Given this list of marker genes Cadm2, Pcmtd1 (protein-L-isoaspartate (D-aspartate) O-methyltransferase domain containing 1), Gvin3, Inpp4a, Ube2c, Slitrk2, Rabl3, Col11a1, Sparcl1, Cfl2, Fsd1l, Nup155, Samsn1, Bicd1, Mmd, Or51m1, Akap6, Ppp3ca, Cpsf6, Klhl23, Papola, Arhgap42, Man1a, Cyc1 (NCBI Gene Id 66445), Btg2, Plppr4, Sgip1, Gpr85, Scai, Pank3 (NCBI Gene Id 211347), Zfp36, Pcdhb14 (NCBI Gene Id 93885), Usf2, Vmn2r121, Csad, Slfn9, Vmn2r89, Chchd4, Gpr180, Ubr5, Serpinb7, Ttc6, Nkiras1, Tob1, Gucy1a2, Psd3 (NCBI Gene Id 80295), Bmp5, Evi2b, Rskr, Cck, Gnai1, Trpm7, Eif1a, Kcnt2, Top1, Ankub1, Vcpip1, Zfp280b, Ndfip2, Pdgfra, Naa50, Vkorc1l1, Pgrmc1, AI597479 (NCBI Gene Id 98404), App, Arl6ip6, Lox, Omg (oligodendrocyte myelin glycoprotein), Fut9, Pggt1b, Yeats2, Hectd2, Immp1l, Ddx3x, Uqcc6 (NCBI Gene Id 544717), Cpeb2, Leprotl1, Ints2, Slc23a2, Dnajc9 (NCBI Gene Id 68076), Epm2aip1, Gpr65, Snrpn, Ret (ret proto-oncogene), Foxn2, Cdkal1, Pdik1l, Plaa, Phip, Cep350, Asxl2 (NCBI Gene Id 75302), Cdk6, Spaca7b (sperm acrosome associated 7B), Gpc6, Scart1, Ptchd4, Papln, Snapin, Ndufs5, Mbnl1, Rbm46, Tvp23b, Suz12, Mex3b, Anxa5, Kdm7a, Inppl1, Tbx5, Prl7a2, Eif5a2 (eukaryotic translation initiation factor 5A2), Slfn8, here is a description of the gene set: Mouse Gene Set: MIR_3066_3P Genes predicted to be targets of miRBase v22 microRNA mmu_miR_3066_3p in miRDB v6.0 with MirTarget v4 prediction scores > 80 (high confidence targets). from publication Chen Y, Wang X (PMID 31504780) studied in species Mus musculus